The following is a description of a gene set: part of: Signaling by MET studied in species Homo sapiens Reactome Pathway: MET activates STAT3 The STAT3 transcription factor binds to activated MET through phosphorylated tyrosine residue Y1356 of MET. STAT3 may also bind to activated MET indirectly through GAB1, but this interaction has not been studied in detail. Activated MET induces phosphorylation of STAT3 at Y705, triggering STAT3 dimerization and nuclear translocation. Endocytosis of MET and interaction with STAT3 at endosomes may be required for sustained STAT3 phosphorylation in response to HGF stimulation. Activated SRC may also contribute to phosphorylation of STAT3 at Y705. STAT3 may promote HGF transcription in a SRC-dependent way, but this autocrine HGF loop may be limited to breast cancer cells. MET-mediated activation of STAT3 is implicated in anchorage independent cell growth and invasiveness downstream of HGF. MET can also interact with STAT1A, STAT1B and STAT5, but the biological importance of these interactions is not known., and this is the list of marker genes: HGF, MET, STAT3